Given this list of marker genes GNPTAB, ARSL, COL2A1, FN1 (NCBI Gene Id 2335), IDUA, MMP2, MADD, SKI, DDR2, here is a description of the gene set: C1-C2 vertebral abnormality Any abnormality of the atlas and the axis. Human Gene Set: HP_C1_C2_VERTEBRAL_ABNORMALITY studied in species Homo sapiens